The following is a description of a gene set: Human Gene Set: REACTOME_SYNTHESIS_SECRETION_AND_INACTIVATION_OF_GLUCAGON_LIKE_PEPTIDE_1_GLP_1 Synthesis, secretion, and inactivation of Glucagon-like Peptide-1 (GLP-1) studied in species Homo sapiens, and this is the list of marker genes: LEP, FFAR1, PCSK1, SEC11A, DPP4, TCF7L2, SPCS3, SPCS2, GCG, GNAT3, GNG13 (NCBI Gene Id 51764), GNB1, CTNNB1, GPR119, CDX2, SPCS1, SEC11C, PAX6, FFAR4, GRP, GNB3